Given this list of marker genes MORC1, ZNF451, HEY2, THRA, HMGB1 (high mobility group box 1), CTNNBIP1, MYC, here is a description of the gene set: Human Gene Set: GOBP_NEGATIVE_REGULATION_OF_DNA_TEMPLATED_TRANSCRIPTION_INITIATION species: Homo sapiens Any process that stops, prevents, or reduces the frequency, rate or extent of DNA-templated transcription initiation.